The following is a description of a gene set: Mouse Gene Set: DMRTB1_TARGET_GENES species: Mus musculus from publication Yevshin I, Sharipov R, Kolmykov S, Kondrakhin Y, Kolpakov F (PMID 30445619), and this is the list of marker genes: Ubtf, Skic8, Ech1, Gm12990, Cdk8, Srpk2, Rps3a2, Nprl2, Gosr1, Slc25a53, Rbm10, Nme1, Hnrnpa1, Srgap3 (NCBI Gene Id 58906), Gm15589, Cdk5rap1, Trmt10c, Atp1b3, Acsbg3, Sspn, Bcorl1, Helq, Rpl36a, Mff, Tmem147, Med27, Zfp113, Mymk (NCBI Gene Id 98857), Mrps18c, Utp15, Man2c1, Ecpas, Zer1, Rpgrip1l, Cep57l1, Stradb, Nif3l1, Eif2b3, Gm15545, Vgf, Rptor, Ints2, Polr2m, P2rx7, 4930473D10Rik, Xpr1 (NCBI Gene Id 19775), Rnf10, Rps6kb2, 1110038F14Rik, Saxo4, Fam227b, BC002059, Gm10309, Abhd4, Utp3, Elof1, Gm17059, Fbxo45, Sorcs2, Abat, Ube2j2, Nfe2l1, Fbxo5, Fra10ac1, Rev1, Gde1, Dlgap5, Dnajc13, Adgrl1, Ints9, Abitram, Ndufs7, Ppp4r1, Ttf1, Gm8624, Cct8, Iqca1l, Il6st, Kdm3b, Mdn1, Psmb5, Prph2, Rgsl1, Fyco1, Eef1akmt3, Zfpl1, Unc5b, Terf1, Atl3, Prmt6 (protein arginine N-methyltransferase 6), Itgb2, Serac1, Gm24172, Prr13, Hmgcs1, Dusp22, Lgr4, Ssbp2, Mir582, Rgs9bp, Gapvd1, Proser1, Naa20, Gm11551, Rce1, Snx7, Nfat5, Cep120, Ptpn11, Gm7467, Rbm47, Hk2, 1700039M10Rik, Dedd, Yipf2, Ankrd16, Gm9958, Usp53, Tut1, Zfp189, Ppp2r5b, Tanc1, Fam91a1, Ess2, Mkln1, Sptan1, Fam149b, Trappc1, Tgm2, Grep1, Fam185a, Actr1b, H2-DMb1, Nherf1, Hdgf, Ginm1, Sik3, Chordc1, Zfp606, Stard3, Gm6485, Cops5, Siah2, Bach2, 2700062C07Rik, Ttc27, Msl1, Mrpl39, Pigc, Mettl26, Gm22122, Gm15706, 1810024B03Rik, Platr4, Btaf1, Usp4, Txnl4b (thioredoxin-like 4B), Tatdn3, 1810008I18Rik, Kbtbd8os, Pfn1, Slc35e4, Slc25a25, Eppin, 9430015G10Rik (RIKEN cDNA 9430015G10 gene), Mapkbp1, Gm26513, Mib2, Nmnat3, Cln8, Ccdc146, Med6, Tango6, Gm27011, Ube2b, Bmi1, Pwwp2a, Mrpl3, Ddx20, Ankhd1, Anapc5, Pum2, H3c13, B4galt3, Mnt, Phip, 1810014B01Rik, Akt2, Igf2r, Gm25855, Zc3hc1, Brwd1, Gm16150, Kctd15, Ccdc80, Gbp8, Bud31, Prcc, Trap1, Pigu, Ppp1r12b, Cblb, Rbpj, Ccar1, Ccdc57, Gpatch8, Gtpbp2, Taco1, Tra2a, Kpna4, Mrpl48, Dimt1, Map1s, Rab5c, Kmt2d, Capn2, Hemk1, Kcnc4, Coil, Cic, Ctu2, Nudt13, Mtg1, Gstcd, Zfp383, Rabac1, Tmem156, Rchy1, Baz1b, Ndufa4, Ccdc92b, Plxna1, Lzic, Rnf7, H3c11, Gtf2h3, Washc4, Kbtbd7, Gm15760, Tmem169, Dync1h1, Pold3, Shc1, Def8, Gar1, Rhno1, Hjurp, Lmf2, Dao, H4c8, Rabggta, Eef1akmt2, Ctu1, Slc9a9, Sp2, Mir6244, Tex2 (NCBI Gene Id 67751), Rbm27, Tex13d, Ttc13, Abhd2, Golga3, D930032P07Rik, Ak2, Hdac5, Larp1b, Gm6712, Atg7, Dlgap4, Mir5101, Calm1, Ankra2, Gm25894, Oaz2, Zbtb11, 1700037C18Rik, Cdca8, Vps51, Myl4, Fam118b, Agtpbp1, 3110031N09Rik, Thap6, Haspin, Nrp2, Zfp143, Polr1has, Snx27, Jmy, Dcaf7, Gm26347, Rab33b, Phb2, Mtf2, Bahcc1, Rbm8a, Tubb5, Hnrnpr, Zc3h3, Khsrp, Ube2e3, Fbxl14, Ggnbp2 (NCBI Gene Id 97681), Ccnf, Odf2l, Nr3c2, Cln5, Calm2, Eif2b4, Bicd2, Ckap5, Zfp367, 1700073E17Rik, Thg1l, Nudc, Iftap, Cwc25, Epo, Mob4, Fmo1, H2bc26, Snrnp27, Drg2, Cep104, Sf3b3, Zfp637, Sesn2, Gm20605, Malat1, Malsu1, Gm15638, Ppp1cc, Gm11718, Rpl18, Nsd3, H1f0, Vps13b, Prdm9, Rbm39, Chchd1, Trpc4ap, Fubp3, Zdhhc4, 1700034P13Rik, Kdm8, Sav1, Cytip, Usp10, Rnf146, Sp1, Paxbp1 (PAX3 and PAX7 binding protein 1), Lpo, Zfp280d, Gm8495, Birc5, Casz1, Eif2s2, Mcee, Zfp623, Entrep2, Bcl2l12 (BCL2 like 12), Map2k6, Smpd3, Myl9, Cdan1, Zfp523, Sar1b, Bclaf3, Shroom4, Urb2, Tmed9, 9030616G12Rik, Pknox1, Tmbim4, Ptpn9, Abi3, Wiz, Ice1 (NCBI Gene Id 97855), Snrpd3, Snord110, Rab5if, Zfp236, Cspp1, Rbm22, Cep97, AA474408, Kxd1, Zfp442, Gnl3, Coq2, Hexim2, Ndufaf1, Uqcc4, Ttc32, Rab21, Calcoco1, Cenpe, Ppig, Vrk1, Ush1c, Prkab1, H4c11, Rnf149, Lclat1, Rbm45, Cdkn2d, Zmynd11, Ralgps1, Zfp106, Atg5, Pdlim5, Gnb2, Gm6543, Krr1, Bnip2, Stat3, Gm18821, Epb41, Dym, Hinfp, Cops8, Prrx2, Rab2a, Gtf2h5, Kansl1l, Fdxacb1, Sphk2, Tsc1, Tle4, Fuca2, 1600014C10Rik, Txnrd1, Aebp2, Ankrd17, Ing5, Rapgef4os2, Vasp, Syncrip, Mapk7, Zfp622, Ccm2, Ankrd27, Clock, 2610307P16Rik, Pecr, Dtwd1, Pds5a, Zfp395, Orai3, Nek9, Gm22504, Phax, Mon1b, Wdr36, Ndufab1, Tnrc18, Rab5b, Ctcf, Ptcd2, Gm5447, Banp, Lonp1 (lon peptidase 1, mitochondrial), Ciz1, Mir5122, Hmbox1, Zfp609, Bloc1s4, Fbxo6, Eapp, Aimp1, Spmap1, Ncaph2, Ahcyl2, Fundc2b, Usp35, Ssbp3 (NCBI Gene Id 72475), Mkrn2 (NCBI Gene Id 97310), Sgce, Phf21a, 3300002I08Rik, Magoh, H2ac8, Ap2m1, Wipf2, Psmg1, Fbh1, Rfesd, Mettl1, Ubr4, Ric1, Gm11736, Slc10a6, Trak2, Tns1, Ctdsp1, Zfp422, Gpr157, Atad1, Slc13a4, Sycp1, Dcp1a, Tcf24, Rap2a, Twf1, Cyb561d2, Adam19, Rnf139, Dmwd, Gucd1, Trpm8, Unc79, Gm14251, Nck1, Mapk9, Gm42918, Hspa8, Diras1, Gbp10, Ube4a, Rdm1, Stx16, Ccdc103, Lasp1, Atxn7l3, Ttc4, Tcf4, Nhlrc3, Sccpdh, Dnajc16, Psph, Dbndd1 (NCBI Gene Id 72185), Eif4a2, Axdnd1, Rora, Ddx52, Pmepa1, Gm26787, Rif1, Calr4, Cdca3 (cell division cycle associated 3), Tspan12, Gm3510, Gm13214, Fat1, Slc1a5, Kmt2a, Gm11613, Sobp, Gm10655, Bik, Nop16, Ube2i, Tram1 (NCBI Gene Id 72265), Gnai1, Tmem250, Erg, Mllt10, Tnfaip6, Otud5, Urgcp, Polr2e, Mphosph10, Septin7, Midn, Acly, Fto, Dmrtb1, Tmem101, Wbp4, Mllt1, Pcbp1, Wasf2, Champ1, Card14, Arid1a, Qtrt2, Prpf4b, Glis3, Zcchc14, Rptoros, Bbs9, Btrc, Arl2, Clptm1l (NCBI Gene Id 218335), Fam219b, Foxm1, Frmd5, Ubac2, Rc3h2, Wdr53, Fbxl18, Itga6, Gatc, Cbx4, Slco2b1, Sh3rf3, Aars2, Gm17197, Bod1, Cdc25a, Ankrd40, BB218582 (NCBI Gene Id 99465), Slc33a1, Cog4, Yeats2, Agfg1, 4930526F13Rik, Ppp1r37, Dcun1d1, Hacd2 (NCBI Gene Id 70757), Kbtbd8, Srf, Rpl23, Wdr70, 1110004F10Rik, Evi5l, 2700038G22Rik, Trerf1, Vezf1, Epc1, Pdap1, Gbp4, Kansl3, Mxd3 (Max dimerization protein 3), Cdkl2, Gm29538, Ift52, Dpf3, Zfp865, Usp5, Slc4a1ap, Btf3l4, Yy1, Vcpip1, 1810044D09Rik, Nup93, Slc4a3, Usp16, Cpd, Trim67, Tmbim6, Zfp951, Rnf167, Zfp384, Nab2, 4933440M02Rik, Zfp131, A430105J06Rik, Mrps5, 2900052L18Rik, Dad1, Dhx38, Pcm1, Myom3, 6530411M01Rik, Pan2, Rbm48, Crebzf, Fbxw11, Plxnb2, Arl5a, Ubqln4, Rufy2 (NCBI Gene Id 70432), Map2k3, Rac1, Atp8b2, Snx3, Tcerg1 (transcription elongation regulator 1 (CA150)), Actl6a, Anp32e, Cox7a2, Ascc3, Mcm9, Rfwd3, Dnajc11, Mplkip, Rwdd3, Pex3, Mgat1, Taf9, Rpl11, Cyth2, Msantd2, Phf13, Ndufs8, Slc13a3, Mir335, Tle3, Gm17552, Usp30, Il4i1, Gas2l3, Atcayos, Trdmt1, Skida1, Dap3, Exo1, Luzp1, Polr1h, Tstd2, Tmem231, Selenok, Gm5766, Pex1, Lgals7, Meis2, Gpcpd1, Ifih1, Ptgfr, Fis1, 2900089D17Rik, Bcl2l2, Dnttip2, Dph1, Nsl1, Elp2, Egln1, Mpnd, Sdhaf3 (NCBI Gene Id 71238), Flad1, Nlk, Cops2, Hus1, Ugcg, Cbll1, Lmod1, Magea10, Cdk2, Gan, Nckap1, Ambra1, Egr4, Pabir1, Ifrd2, Srp19, Sugct, Clpb, Ddc, Acta2, Mir8109, Cdk20, Rnf6, Cyp11a1, Kbtbd2, Trim37, Nav2, Slc44a1, Triap1, Trim23, Shb, Phf3, Denr, Brd10, Arhgef2, Man1b1, Rnf38, Lsm12, Pcyt1a, Osbpl1a (NCBI Gene Id 64291), Katnal1, Spdl1, Vamp4, Dis3l, Tbkbp1, Asb7, Rpl9, Axin2, Mex3a, Tdp2, Rhbdd2, Ints6 (NCBI Gene Id 73038), H3f4, Timm10, Ezr, Obi1, Ddx39b, C330018A13Rik, Capzb (capping actin protein of muscle Z-line subunit beta), Dnajc2, Bdp1, Rnf113a2, Lhx4, Dhx29, B4galt7, Lrch4, Yap1, Nuf2, 1700084C06Rik, Fryl, Kmt5a, Rlf, Wdr6, Kif1b, Cacnb3, Mad1l1, Lats2, Satb1, Susd6, Nrarp, Etnk2, Ccdc9, Ftdc1, Slc25a22, Rab29, 0610040B10Rik, Smu1, Rhbdd3, Brd2, Rps7, Ptma, Naa35, Camkmt, Gm11827, Gngt2, Atp5mc3, 4930519P11Rik, Rab11b, Rictor, 0610043K17Rik, Lrba, Nans (N-acetylneuraminic acid synthase (sialic acid synthase)), Npepps, Cx3cl1, Nsfl1c, Trappc13, Gtf3c3, Eldr, Cdk12, A830035A12Rik, Mxra7, Ccdc126 (NCBI Gene Id 58912), Atxn3, Zng1, Atp6v1g2, Nup42, Nkd2, Zbtb40 (zinc finger and BTB domain containing 40), Dlat, Vps25, 4930558K02Rik, Rexo4, Slc9a1, Glrx2, Cep19, Ttll4, Klhdc2, Msl2 (MSL complex subunit 2), Pramel6, Chd2 (chromodomain helicase DNA binding protein 2), Kif22, Gm22979, Snrpd1, Gga2, Ywhaz, Thra, Tm2d3, Trp53rka (transformation related protein 53 regulating kinase A), Eloc, Cggbp1, Polg, Mrpl58, Slc39a6, Emc7 (NCBI Gene Id 98979), Scgn, Tmem94, Cnot10, Morf4l1, Kras, Tmem230, Garin2, Rars1 (arginyl-tRNA synthetase 1), Ctnna1, Gm8241, Nras, Supv3l1, Selplg, Dpy19l4, Rplp0, E130307A14Rik, Sppl3, Mtrex, Eif2b1, Gm4535, Mir6541, Nup153, Cfap36, Ston1, Pprc1, 5430405H02Rik, 1810041H14Rik (RIKEN cDNA 1810041H14 gene), Bbs5, Ak6, Eri3, Dffb, Gm11175, Ppil4, Ube2v1, 9430097D07Rik, Gm5161, Kat6a, Tsen15, Rpgrip1, Ltbp3, Eif2ak3, Spc24, Prkag1, Nfkbia, Pithd1, Cops4, Elovl2, BC030343 (cDNA sequence BC030343), Gemin6, Rpl13a, Tardbp, Krt75 (NCBI Gene Id 76250), Hnrnpl (NCBI Gene Id 97377), Fnbp4, Gbp9, Klf13, Stat1, Prss48, Prpf19, 1700003D09Rik, Tspan9, Blvrb, Golm2, Pi4kb, Trrap, Fbxo40, Syt2, Eif4e2, Capza2, Atxn2, Pou6f1, Brca2, Slc3a2, Slc39a3, Faf2, Lsm6, Reps1, Nfyb, Srcap, Ino80b, Cops7b, Gm30270, Cux1, Cct6a, Dhx16, Gm23382, Zfp207, Secisbp2, Taf5l, Mrpl2 (mitochondrial ribosomal protein L2), Rad17, Mrpl50, BC051077, Kif2c, Gnaz, Tbck, Erlin2, Eif4g3, Galk2, Fbxo42, Cops3, D030040B21Rik, Psma3, Ash1l, Ccdc191, Tomm6, Degs1, Smg9, Mbip, Mrps27, Sco2, Odc1, Hcrtr2, Tubgcp6, Tmod1, Dmrt1, Zfp354c, Dpep3, Tma7, Acy1, Psmf1, Plxna3, Gm10433, Ran, Platr27, Ube2k, Haus6, Got1, Fxr2, Slc35b4 (NCBI Gene Id 75817), Oxsm, Psmc4, Lias, Appl2, Slc35a3, Hnrnpa0, Tcim, Naf1, Sharpin, Snx17, Ffar2, Mest, Hint2, Onecut1, Kat6b, Tmprss5, Eya2, 1700069L16Rik, Slc35e3, Senp1, H2af-ps2, Gls, Cntrob, Slc25a11, Psmb2, Zcchc8, Igf2bp2, Gata5os, Zfp316, Ivd, Tbx3os1, Stt3a, Maf1, Ruvbl2, Dctn5, Ngly1, Tmem147os, Rsad1, Ppp6c, Ndel1, Atf5, Ktn1, Gtpbp10, Rtcb, Mkln1os, Snora21, Snrnp200, Arhgap18, Mrpl1, Itgb8, Srrm2, Chmp4b, Cdca5, Srrd, Clint1, Pnrc1, Auts2, 5730455P16Rik, 4933424G06Rik, Mei1, Fbxw7, Pmepa1os, Elavl2, Nubpl, Tsn, Elp1, Lpcat1, Adrm1, Esyt2, Dll3, Eftud2, Lin9, Rad54l2, Wnk1, Emg1, Mtmr4, Arhgap39, Acsbg2, Ube2d2a, Ankrd44, Cfap68, Unk, Setx, Thap11, Opa1, Snx12, Npc1, Mrpl45 (NCBI Gene Id 97774), Tpk1, Rpl36, Cep70, Exoc2, Mrpl12 (mitochondrial ribosomal protein L12), Gm17491, Guf1, Mir8095, Cpsf1, Itgb4, Col26a1, Gm34767, Caprin2, Sgk3, Kif1a (kinesin family member 1A), E330020D12Rik, Nfx1, Per2, Mir17hg, Hnrnpd, Eif5, Abca5, Trmt12, Stk11, Cbx5, Xylt2 (NCBI Gene Id 217119), Klhdc10, Cish, Nmnat1, Xpo4, Ap3d1, Phb1, Get1 (NCBI Gene Id 93958), Camta1, Abi1, Niban3 (niban apoptosis regulator 3), Tomm7, Rev3l, Mlxip, Jarid2, Gm26901, Smap2, Ubb, Mnat1, Arv1, D5Ertd579e, Zfp809, Ssr2, Adipor1, Stau1, Dhx58os, Vangl2, Nfatc2ip, Gm12279, Dcaf15, Sohlh2, Cacna2d1, Yes1, Rpusd4, 6330549D23Rik, Fam20b, Nop56, Foxa3, S100z, Pkn2, Psmc2, Fmc1, Ints12, Pygo2, Tbp, Sympk, Mbd3, Cluap1, H3f3a, Ccnc, Ppil3, 4930571N24Rik, Adnp, Fbxo48, Ano7, Gm22362, Nos1ap (nitric oxide synthase 1 (neuronal) adaptor protein), 1600020E01Rik, Pacs2, Pabpn1, Fam107b, Gm11335 (predicted gene 11335), Ahcyl1, Mir1893, Kctd21, Serhl (serine hydrolase-like), Akap1, Gtpbp1, Pim3, Sfr1 (SWI5 dependent recombination repair 1), Gm11936, Emc3, Cdk17, Zscan2, Rcc2, Fxyd3, Acot13, Lpcat3, Zfp260, Gm15787, Elmo2, Prepl, Sass6, Syne2, Gm10524, Arf4, Ppid, Rnf166, Ddost, Aopep, Plekhg5, Mettl9, Cks2, Srrt, Ecd, Prkacb, Sec24b, Bms1, Myrf, Grwd1 (glutamate-rich WD repeat containing 1), Lamtor2 (NCBI Gene Id 83409), Dcaf10, Trp53rkb, Phf14, Rasal2, Frs3, Syp, Necab1, Ccdc50, Parp12, B130034C11Rik, B3galnt2, Parl, Atf2, Gm9828, Zfp560, Supt7l, Limk2, Myzap, Det1, Fancd2, Nipsnap2, Hnrnpk, Palb2, Mir17